Given this list of marker genes TNFRSF9, IGFLR1, RN7SL809P, MCOLN2, IRF8, BTLA, FMNL1-DT, NAP1L4P1, MMP9, FMR1NB, PDCD11, MS4A15, ENSG00000258039, C10orf88B, NME8, RPL32P1, SNX20, PLEKHM3, MMP2-AS1, AIRE, C1orf54, ADAM8, KDM2B, LAMP3, RN7SL172P, FASTKD5, HLA-DQA2, CLECL1P, BCAS2P2, OASL, RNU6-1228P, NUP62, ATG3 (NCBI Gene Id 64422), AKR1E2, CD70, CLIP1-AS1, ELAC2 (elaC ribonuclease Z 2), LINC00487, SLAMF7, HLA-DQB1, ENSG00000215156, RN7SL288P, H2BC3, SLC12A3, TRAF1, LINC03052, WNT5B, RPS12P4, LINC02877, ENSG00000235979, GCSAM, CD74, DTNB-AS1, SLC9A7, POGLUT1, MRM3, RN7SL211P, TIFAB, VAC14, RSC1A1, ZMIZ2, RFTN1, MMP25, FLT3, EPSTI1, PPM1J, FCHSD2, HLA-DOB, ARAP1-AS1, ZMYND15, IL21R (NCBI Gene Id 50615), GAS5-AS1, RPL31P12, RNU6-523P, NAP1L1P1, CD80, HSALR1, NAAA, ALYREF, TMCC3, IKBKE-AS1, RNU6-172P, GNA15-DT, NME2P1, TANK, IL12B, TOR3A, C2orf69, GFI1, EVI2A, RGS13, LINC01845, TIAM1-AS1, RPS26P21, IL4I1, RPS4XP16, WDFY4, NMI, FLJ40194, FUT7, RN7SL45P, ERICH1, RPS27AP12, MTATP8P1, HLA-DRB6, LINC01010, ARHGAP22, SLAMF8, HLA-DPA1, RNU7-45P, PRDM15, AICDA, ENSG00000267039, XCR1, MIR155HG, RAB8B, ENSG00000232628, CCL22, AEN, ZNF366, YES1P1, LINC02096, ENSG00000245025, ENSG00000227531, TWF1P2, NDE1, HLA-DPB1, SWSAP1, RASSF2, GPR132, AFTPH-DT, VOPP1, MS4A6E, RNU6-1284P, PLA2G2D, RPL4P6, ENTHD1, BNIP3P5, BMS1P4, CLEC16A, LINC01816, RPL31P11, DENND1B, POLR3DP1, CCL17, P4HA2-AS1, RPL23P8, N4BP2L1, CXCL9, ATG16L1, CXCL10, SEMA4A, RNF19B, SAMD9L, ENSG00000231873, CCR7, SORD2P, DM1-AS, CD40, RPL21P48, HLA-DQB2, NUB1, here is a description of the gene set: studied in species Homo sapiens The gene expression program underlying the specification of human cell types is of fundamental interest. The study authors generated human cell atlases of gene expression and chromatin accessibility in fetal tissues. For gene expression, the study authors applied three-level combinatorial indexing to >110 samples representing 15 organs, ultimately profiling ~4 million single cells. The study authors leveraged the literature and other atlases to identify and annotate hundreds of cell types and subtypes, both within and across tissues. Our analyses focused on organ-specific specializations of broadly distributed cell types (such as blood, endothelial, and epithelial), sites of fetal erythropoiesis (which notably included the adrenal gland), and integration with mouse developmental atlases (such as conserved specification of blood cells). These data represent a rich resource for the exploration of in vivo human gene expression in diverse tissues and cell types. Human Gene Set: DESCARTES_MAIN_FETAL_ANTIGEN_PRESENTING_CELLS Marker genes curated from the annotated cluster as represented in the Descartes Human Gene Expression During Development database. from publication Cao J, O'Day DR, Pliner HA, Kingsley PD, Deng M, Daza RM, Zager MA, Aldinger KA, Blecher-Gonen R, Zhang F, Spielmann M, Palis J, Doherty D, Steemers FJ, Glass IA, Trapnell C, Shendure J (PMID 33184181)